Given this list of marker genes TWIST1, SEC24C, JMJD1C, COMT, FGFR2, ERF, ARVCF (NCBI Gene Id 421), TBX1, GP1BB, RREB1, HIRA, UFD1, here is a description of the gene set: species: Homo sapiens Multiple suture craniosynostosis Craniosynostosis involving at least 2 cranial sutures, where the exact pattern of sutures fused has not been precisely specified. Human Gene Set: HP_MULTIPLE_SUTURE_CRANIOSYNOSTOSIS